The following is a description of a gene set: Genes predicted to be targets of miRBase v22 microRNA hsa-miR-217-3p in miRDB v6.0 with MirTarget v4 prediction scores > 80 (high confidence targets). species: Homo sapiens Human Gene Set: MIR217_3P from publication Chen Y, Wang X (PMID 31504780), and this is the list of marker genes: PPP2R1B, ZMYND11, KLRC1, PTPRE, ZNF236, GIGYF2, EIF4E, SLCO1C1, CCNB3, KBTBD11, NPHP1, HIPK1, MED6, C12orf50, SPIN3, KDSR, ITCH, MTARC1, MEIOC, TMPRSS11F, RHBDD1, DPH6, ZFYVE16, OPRM1, EIF2AK3, GALNT1, CALHM4, UBA5, HNRNPU, SAMD12 (sterile alpha motif domain containing 12), SYTL4, SLC41A1 (NCBI Gene Id 254428), ITGA9, DARS2, SGMS1, KIAA0232, EIF1AX (NCBI Gene Id 83754), TNFAIP8, CHML, POU2F1, CCER1, STAT1, AFP, SIGLEC14, NEIL1, ZNF330, C5orf24, CACHD1, ZNF746, NFYB, CARF, CABYR, GCA, BCL11A, TSPYL4, PIAS2, PTPRG, EEA1, MLLT3 (NCBI Gene Id 4300), NDST3, UBE2D3, KCNA4, WDR75, ZNF180, RFX8, IRAK4, CDH2, SPOPL, H2BC5, CASP8AP2, NQO1, CNTN1, FOXP2, KALRN, GALK2, WASHC5, RIT1, ARL10, PLPPR4, C7orf57, SPRY2, YES1 (YES proto-oncogene 1, Src family tyrosine kinase), APPL1, SUV39H2, TRDN, RNF168, MYO6, PHF20L1, HOXC6, MYEF2, FAM76B, SLC9C2, FGFR1OP2, ERI2